Given this list of marker genes DEFB114, TRIB1, LILRA2, CACTIN, ACOD1, SIGIRR, PTPN6, DEFB118, PRDX2, TNFAIP3, SIRPA, NFKBIL1, CARD16, CARD8, LTF, LACRT (lacritin), here is a description of the gene set: Any process that stops, prevents, or reduces the frequency, rate or extent of signaling in response to detection of lipopolysaccharide. Human Gene Set: GOBP_NEGATIVE_REGULATION_OF_LIPOPOLYSACCHARIDE_MEDIATED_SIGNALING_PATHWAY studied in species Homo sapiens